Given this list of marker genes SLC29A3, CCDC34, SPATA22, ANOS1, TERB2, KLHL10, SOHLH1, TAC3, MOV10L1, LRRC23, FANCA, CATIP, PMFBP1, CFAP47, FKBP6, NR0B1, CATSPER2, CT55, PROK2, DNAH17, SPAG17, SPRY4, CFAP70, NNT, GCNA (NCBI Gene Id 93953), KASH5, KISS1R, DNAH10, BRCA1, CEP19, HFE, BRWD1 (NCBI Gene Id 54146), CYLC1, LHCGR, IFT74, ZSWIM7, MSH4, PDE11A, CCIN, FANCE, DAZ1, POR, NANOS1, ARMC12, NR3C1, ANTXR1, TEX15, STK11, MSH5, STK33 (serine/threonine kinase 33), TDRD9, ARMC2, WNT4, FANCL, FANCD2, FANCC, FANCI, DNHD1, ATM, WEE2, TERB1, TUBB8, SPINK2, HS6ST1, CHD7, SYCE1, PDHA2, C14orf39, TACR3, NR5A1, CFAP91, GATA4, MRAP, XKRY, FGFR1, CFAP65, MCM8, PNLDC1, PROKR2, NHLH2, DAZ2, BMP2, RPS4Y2, SCP2, PANX1, GNRH1, TAF4B, CDY1, SEPTIN12, USP9Y, DAZ4, PATL2, MAP3K1, BRCC3, DZIP1, CCDC146, MAD2L2, FANCM, RAD51C, BRCA2, DHX37, WDR11, SYCP3, AR, FSHB, SOX9, STRC, FGF17, GNRHR, CFAP61, BRIP1, MC2R, TEX14, STAG3, SHOC1, DAZ3, BLM (BLM RecQ like helicase), VCY, NSMF, HSD3B2, XRCC2, TEKT3, WWOX, DDX3Y, HJV, RBMY1A1, FANCF, PRKAR1A, CATSPER1, DNAH9, VAMP7, FGF8, CDY2A, HSFY1, RPL10L, POC1A, TEX11, FBXO43, OCRL, FANCB, RNF212, BCL10 (BCL10 immune signaling adaptor), FGFR3, STAR, KIT, FANCG, STEAP3, ERCC4, MEIOB, CNBP, KDM5D, CFTR, DRC1 (dynein regulatory complex subunit 1), KCNU1, CLDN2, ALMS1, ZFPM2, SLX4, SEMA3A, GBA1, SRY, SYCP2, ZMYND15, PALB2, UBE2T, LHB, RFWD3, ADGRG2, DUSP6, KISS1, SUN5, WT1, ANK1, TXNRD2 (thioredoxin reductase 2), HNF1B, TSPY1, M1AP, RAD51, BPY2, here is a description of the gene set: Human Gene Set: HP_ABNORMAL_SPERMATOGENESIS Abnormal spermatogenesis Incomplete maturation or aberrant formation of the male gametes. species: Homo sapiens